The following is a description of a gene set: from publication Chen Y, Wang X (PMID 31504780) Genes predicted to be targets of miRBase v22 microRNA hsa-miR-6512-3p in miRDB v6.0 with MirTarget v4 prediction scores > 80 (high confidence targets). studied in species Homo sapiens Human Gene Set: MIR6512_3P, and this is the list of marker genes: CROT, SLC19A3, PLK2, UBE2D3, SWSAP1, METTL13, PHF1 (NCBI Gene Id 5252), SLAMF1, NR3C1, MYCL, MDM4, OTX2, EHBP1, SMCR8, TMEM106C, ZC3H12C, AKAP12, ZMYM2, PCGF3, IPCEF1, RBPJ, ZNF180, AGPAT1, ORAI2, RNF144A, WWC3, FOXP4, STON1, CAMK2A, SLC12A7, ENTPD1, JRK, GPLD1, TMEM88, PSME3, SRSF4, KIF16B, RBFOX2, SLC39A10, SMAD4, ZNF217, FGF7, ZNF20, VPS53, ZSCAN29, DIP2B, MAGI3, TM6SF1, CCDC71L, CUL5, NXT2 (NCBI Gene Id 55916), ZSWIM8, ESRRB (NCBI Gene Id 246148), MACIR, BAGE2, SULT4A1, SLCO5A1, WDR37, LRFN1, FCHSD1, UBE2G1, VCAN, EXO5, STMN4, SH3TC2, TRAF4, EFCAB2, RBMS2, CEACAM7, FABP2, SPTSSB, STRADA, ARFGAP2, SGPP2, STPG4, LRIG1, NAT9, BACE2, SDC1, SMARCD1, C1QTNF3, TSGA10, CHSY1, IL1RL2, RCBTB1, SLC24A4, CEACAM6, KDM5B (NCBI Gene Id 10765), MSANTD4, SHISA6, RAP1GDS1, DHX36, GPT2, PDCD4, FAAP20, ARPC2, ELP6, CMPK1, CCDC6, AKT3, UMPS, SESN1, EIF2S2, LUZP1, DAB2IP, LETM1, XRCC3, MMP13, ZDHHC2, SALL1, MTARC1, TNRC6C, PIK3C2B, NPM1, ADD1, LASP1 (LIM and SH3 protein 1), SAMD12, OR51E2, UBE2Q1, MRPS7, AAK1, PNKD, TRIM8, PSTPIP2, RAP1GAP2, F11R, TPM1, IRGQ, C1orf21, ADORA3 (adenosine A3 receptor)